The following is a description of a gene set: The process by which the mitochondrial outer membrane becomes permeable to the passing of proteins and other molecules from the intermembrane space to the cytosol as part of the apoptotic signaling pathway. Mouse Gene Set: GOBP_MITOCHONDRIAL_OUTER_MEMBRANE_PERMEABILIZATION studied in species Mus musculus, and this is the list of marker genes: Gsk3a, Tmem14a, Vdac2, Siva1, Slc35f6, Tmem102, Zfp13, Fzd9 (frizzled class receptor 9), Atp5if1, Bnip3, Rhot1, Slc25a31, Acaa2, Bnip3l, Bak1, Chchd10, Rhot2, Bok, Ier3, Bid, Gsk3b, Gclc (glutamate-cysteine ligase, catalytic subunit), Mpv17l, Hip1r, Bcl2l1, Mul1, Bloc1s2, Slc25a5, Eya2, Slc25a4